Given this list of marker genes FXYD2, ECSIT, GTF3A, TMLHE, HINT2 (histidine triad nucleotide binding protein 2), PHPT1, CD72, NDUFA4, EEFSEC, ERO1B, TIMM13, PAK1, OSGIN1, SLC11A1, MCOLN2, KIF3A, HSCB, TFB2M, ACTR6, DDIT4 (NCBI Gene Id 54541), HSPE1 (NCBI Gene Id 82869), INTS6L, PPT2, TRAM1, IDO1, TMEM147, TEX261, UBAC2, CEBPZOS, PYROXD1, SUPV3L1, PSPC1, DHDDS, TMEM97, PCYT1A, CD68, SIGLEC7, DTX3, ZBTB8OS (NCBI Gene Id 339487), UBAP2, NSMCE3, TSR2, UFC1, TOMM40L, DPH5, MRPL57, CHADL, EPHA1, NOSIP, OAZ1, RPL9, HLA-C, HEXB, ACBD6, MRPS2, ANAPC1, DTD1, HLA-DOA, DRG2, METTL5, SKIC8, GCLC, HDGF, HEXIM1, BSCL2, ENDOG, NUDT1, CDC16, SNAPC2, FTL, NUP133, POT1, SH3BGRL2, NME7, FAHD1 (NCBI Gene Id 81889), ACOX1, FKBPL, ABHD17A, KDELR1, ARMC1, GUCA1A, UQCRB, ADCY9, PKM, MED31, GLOD4, FTSJ1, GHITM, SLAMF6, CSTF1, NPM1, EXTL2, TBCEL, SDHAF4, MRPS34, TRIAP1, ECI1, CEP20, NAXE, CARMIL1, SEC62 (SEC62 homolog, preprotein translocation factor), RHOD, RDH11, SLC25A20, SUGT1, MAPK14, OSBPL9, OPLAH, TPRKB, TM2D2, DDRGK1, WBP1, TRIM27, NUFIP1, SYNJ2BP, TDP1, TMEM126A, NCF2, HFE, MSRB1 (NCBI Gene Id 51734), UBXN10, MAST3, STK24, IVNS1ABP, SIX1, HSPA4L, DNPEP, SEC11A, COX7A2L, MRPL19, GLCE, GPSM3 (NCBI Gene Id 63940), IREB2, ODR4, MAGOH, CHST15, TPRN, CDK11B, CNMD, SORD (sorbitol dehydrogenase), GMNN, LRBA, C5orf52, SMPD5, C6orf136, FAU, TMEM33, NDUFS6, UBA2, TTC5, SETD6 (SET domain containing 6, protein lysine methyltransferase), SEC61A2, OGA, HMG20A, XPC, MS4A1, YIPF1, C5orf34, ENTPD4, ING3, TLE5, LHX8, PKP2, TMA7, YPEL3, CAT, DDT, CISD1, SNHG11, TRIM69, LRPPRC, DRG1, ANTKMT, COQ3, MTCH2, GLO1, MRPL9, TTC1, LDAH, CINP, ARL8B, CCDC107, SLC16A1, COQ10A, CXCL2, DERL2, BRIX1, ALG1, HNRNPC, BTG2, TP53INP1, KLHL7, JAGN1, POLR3K (RNA polymerase III subunit K), PPCDC, HTR2B, CD1D, ALDH7A1, AURKAIP1, TEX10, here is a description of the gene set: Genes down-regulated in comparison of dendritic cells (DC) stimulated with LPS (TLR4 agonist) at 12 h versus those stimulated at 24 h. Human Gene Set: GSE17721_12H_VS_24H_LPS_BMDC_DN species: Homo sapiens mouse primary BMDCs were stimulated with tlr ligands and gene expression changes were profiled on Affymetrix arrays from publication Amit I, Garber M, Chevrier N, Leite AP, Donner Y, Eisenhaure T, Guttman M, Grenier JK, Li W, Zuk O, Schubert LA, Birditt B, Shay T, Goren A, Zhang X, Smith Z, Deering R, McDonald RC, Cabili M, Bernstein BE, Rinn JL, Meissner A, Root DE, Hacohen N, Regev A (PMID 19729616)